The following is a description of a gene set: Human Gene Set: GOMF_GDP_BINDING studied in species Homo sapiens Binding to GDP, guanosine 5'-diphosphate., and this is the list of marker genes: VPS9D1, RAP1B, DOCK6, RAPGEFL1, SMCR8, SERGEF, EIF2B1, RGL2, DIRAS1, SESN2, GDPGP1, TIAM1, ARHGEF10L, RAB5A, PLCE1, RHOB, EPS8L2 (NCBI Gene Id 64787), DIRAS2, DYNC1LI1, TBC1D10A, FGD4, UCP2, RANBP10 (NCBI Gene Id 57610), PLEKHG2, ALS2, ARHGEF19, PLEKHG4B, MCF2L, DOCK7, FRMD7, ECT2L, MCF2, DENND4C, CYTH3, SLC38A9, IQSEC2, DNM1, CHML, GNAI3, SH2D3C, ARHGEF28, DIRAS3, AKAP13, ARHGEF16, EEF1D, RABIF, RAB3GAP2, RAB3IL1, DOCK11, TIAM2, RAB5C, HERC1, RAB35, PSD4, ARHGEF4, RGP1, DOCK2 (dedicator of cytokinesis 2), RAB27B, MCF2L2, RALGDS, SWAP70, GPSM2, IQSEC3, ARHGEF18, PSD3, FGD6, VAV3, FGD5, SOS2, RAB10, DNMBP, RAB9B, HERC2, ANKRD27, NUCB2, RAP2C, PLEKHG4, FARP2, HPS1, RCBTB2 (RCC1 and BTB domain containing protein 2), NET1, GRIPAP1, PLCG1, EIF5, ARHGDIG, DENND6B, RANBP1, ABR, RASGRF1, PCP2, EIF2B2, RAB17, EGF, EPS8L3, ADRA2A, DOCK9, GBP1, RAB27A, SOS1, RAP1A, TAGAP, PSD2, RASL12, RAB8A, DENND2B, ARFGEF3, KIAA1755, SBF1, ARHGEF25 (Rho guanine nucleotide exchange factor 25), RGS14, PLEKHG5, CHM, RAB12, SPATA13, RABGEF1, GBF1, RCC1, ARHGEF2, TBXA2R, SRP54 (signal recognition particle 54), TRIM23, NME2, RAB22A, MON1A (MON1 homolog A, secretory trafficking associated), DOCK1, RRAGC, RAPGEF5, DEF6, ARHGEF3, EIF2B5, RHEBL1, EIF2B3, ARHGEF17, RHOU, DENND1C, RAB9A, RRAS, PLCD4, ARHGEF38, RAB29, ARHGDIA, ARHGEF26, RANGRF, ARFGEF2, RAB8B, DIS3, RPGR, PLEKHG3, ARHGEF9, RHEB, RAB28, DENND1A, SH3BP5L, PLEKHG6, GNA13, RAB14, UCP1 (uncoupling protein 1), DENND5A, DENND2C, ARFGEF1, BCR, RIN1, NGB, SH3BP4, PSD, GEM, NRAS, ADRA2C, LAMTOR2, ARL2 (ADP ribosylation factor like GTPase 2), PREX1, CYTH2, RGL3, P2RY12, RALGPS2, CYTH4, RHOD (ras homolog family member D), ARL8B, RASGEF1B, DENND2D, PTGIR, ARHGEF11, ARHGEF10, ARHGDIB, ARHGEF15, GNAT1, RIT2, GNAI1, RAB42, RAPGEF3, IQSEC1, DENND1B, RASEF, PLEKHG7, FARP1, ITSN2, RINL, RAP2B (RAP2B, member of RAS oncogene family), DOCK3, RAPGEF6, ALS2CL, RAB31, RASGRP3, RIC8B, HRAS, SBF2, LAMTOR3, ARF6, RAPGEF4, KRAS, CCDC88C, EIF2B4, DENND11, GDI2, DOCK8, RIC8A, RAB5B, EEF1B2, RAP2A, ARHGEF37, FBXO8, KNDC1, RAB18, SEPTIN12, RAB2A, DENND4A, RAB3IP, BCAR3, DOCK10, VAV2 (NCBI Gene Id 7410), WDR41, RAB11B, SUCLG2, RCC2, LAMTOR4, LAMTOR5, RAB21, RALA, ARHGEF5, NUCB1, RIN2, RGL4, NGEF, DOCK4, ITGB1BP1, MADD, RAP1BL, PREX2, RIN3, ARF4, ARHGEF40, ERAS, RERG, MYCBP2, HPS4, PREB, CCZ1, FGD3, MRAS, RAPGEF2, RASGEF1A, DENND3, VAV1 (NCBI Gene Id 7409), PLEKHG1, SH3BP5 (SH3 domain binding protein 5), RASGRF2, MIEF1, RASGEF1C, RASGRP4 (NCBI Gene Id 115727), SH2D3A, KALRN, RRAS2, ARHGEF12, TRIO, C9orf72, ARHGEF39, FGD2, FGD1, ITSN1, RIT1, THG1L, GDI1, DEPTOR, LAMTOR1, ARL3, GCGR, OBSCN, DENND4B (DENN domain containing 4B), DOCK5, RHOF, GAPVD1, ARHGEF7, RAB7A, DENND5B, ELMO1, RASGRP2, DENND10, RALGPS1, RRAGD, CYTH1, ECT2, DENND2A, RAN, RAB3B, RCC1L, RAP1GDS1, SEC61B, CCDC88A, RALB, ARHGEF33, RAB3GAP1, RASGRP1, RIC1, RAPGEF1, EPS8L1, RAB4A, ARHGEF6, GPSM1, DENND6A, ARHGEF1, RGL1